The following is a description of a gene set: The development, homeostasis and function of B lymphocytes involve multiple rounds of B cell receptor (BCR)-controlled proliferation and prolonged maintenance. We analyzed the role of transcription factor Zfx, a recently identified regulator of stem cell maintenance, in B cell development and homeostasis. Conditional Zfx deletion in the bone marrow blocked B cell development at the pre-BCR selection checkpoint. Zfx deficiency in peripheral B cells caused impaired generation of the B-1 cell lineage, accelerated B cell turnover, depletion of mature recirculating cells, and delayed T-dependent antibody responses. Zfx-deficient B cells showed normal proximal BCR signaling, but impaired BCR-induced proliferation and survival. This was accompanied by aberrantly enhanced and prolonged integrated stress response, and delayed induction of Cyclin D2 and Bcl-xL proteins. Thus, Zfx restrains the stress response and couples antigen receptor signaling to B cell expansion and maintenance during development and peripheral homeostasis. Human Gene Set: GSE13547_WT_VS_ZFX_KO_BCELL_UP from publication Arenzana TL, Smith-Raska MR, Reizis B (PMID 19329779) studied in species Homo sapiens Genes up-regulated in B lymphocytes: wildtype versus ZFX., and this is the list of marker genes: CYLD, ABTB2, JAK1, PFDN5, KCNJ8, CCNT2, SCNN1A, EIF4A2, EPHX1, GALP, DST, ARHGAP31, SLC23A2, PLOD2, DNAJC9, IKZF2, AKT3, IL4, PAQR9, FYN, CAMP, FRY, SNX29, SPRY3, XCL1, OXR1, SMAD4, SYT11, KIF5C, CELA1, CDYL, ADGRG1, IDUA, PTTG1, FRMD4B, PLEKHA1, RGS1, ENDOU, TJP2 (tight junction protein 2), DDX60, CD226, TRIM5, PACSIN1, RGS2, RBL2, PHF13, LCLAT1, CCDC88C, HNRNPH3, CD200R1L, TRAPPC12, CACNA1E, TEC, NEDD9, RHOH, SOSTDC1, CHD3, CD3G, LIN28A, SUOX, DGKI, INPP5F, EOMES, IL6ST, STIM2 (stromal interaction molecule 2), DAPK2, GLCCI1, IL10, PNPLA7, ITPR2, NRP1, TNFSF4, TOX, RPS29, ST6GALNAC3, STRN, PRR5L, IFIH1, BAZ2B, CYTH3, CHD9, HLCS, CPEB2, CD55, SRGAP3, CCND2, CACNA1G, PTGER2, SSPN, CD7, ZBTB7A, TOX2, TBC1D17, FAM78B, IGHG3, CREG2, LRIG1, INPP4B, IER3, SLPI, SCD, MX1, LRRFIP2, ACCS, AKAP8L, MEF2C, JCHAIN, CALCOCO1, SEPTIN4, ZBTB4, RHEBL1, DERL3, NSMAF, CD101, ISG20, DNASE1L3, RAB5B, ACE, ITM2A, LAPTM4A, S100A9, OCIAD2, LATS2, CCL5, TMEM37, IFNAR2, YPEL5, CD200R1, SEC24A, RAB6B, RNF167, LTF, LAX1, RUFY4, RUFY2, LBH, GPAM, NKX3-1 (NCBI Gene Id 4824), SNN, S1PR5, MEIS3, PHETA1, YPEL3 (NCBI Gene Id 83719), PCMTD1, CHIC2, IFI27L1, SECISBP2L, PIAS1, ZEB2, ARMCX3, CD83, AIM2, TRPS1, ARFGEF1, RAP1GAP2, RNF2, TBC1D5, KLF3, GOLGA4, CD38, CCL4 (C-C motif chemokine ligand 4), ARID3A, ARL4C